The following is a description of a gene set: An elevation in bone density in one or more phalanges of the fingers. Sclerosis is normally detected on a radiograph as an area of increased opacity. species: Homo sapiens Human Gene Set: HP_SCLEROSIS_OF_FINGER_PHALANX Sclerosis of finger phalanx, and this is the list of marker genes: EIF2AK3, TRPS1, ERCC8, ERCC6, SRCAP, TONSL, GJA1, NGLY1 (NCBI Gene Id 95041)